Given this list of marker genes ADSL, RASSF9, TMEM68, PIK3R4, TNFSF8, RPRD2, here is a description of the gene set: species: Homo sapiens Human Gene Set: MIR516A_5P from publication Chen Y, Wang X (PMID 31504780) Genes predicted to be targets of miRBase v22 microRNA hsa-miR-516a-5p in miRDB v6.0 with MirTarget v4 prediction scores > 80 (high confidence targets).